Given this list of marker genes FERMT1, APC2, PQBP1, CTCF, DKC1, NSD1, ERMARD, EIF4A2, KDM6A, CENPT, KMT2D, SIN3A, here is a description of the gene set: Phimosis Human Gene Set: HP_PHIMOSIS The male foreskin cannot be fully retracted from the head of the penis. studied in species Homo sapiens